Given this list of marker genes TRAPPC4, ADORA1, FZD3, PPFIA3, LPAR2, SYP, FLOT1, NAPA, RIMS1, CACNA2D1, RAB3A, SLC17A7, RIMS4, EGFLAM, ERC1, SYT1, STX19, GABRB1, PCLO, NUFIP1, SYT11, ITGA3, GRIA1, ADORA2A, PI4K2A, ERC2, APBA1, NTNG2, DAO, EHD1, CPLX3, CTNNB1, PPFIA4 (NCBI Gene Id 8497), PNISR, STX2, BRSK1, SV2A, RYK, NECTIN1, UNC13A, KCNJ8, GPM6A (glycoprotein M6A), P2RY1, CACNA2D3 (NCBI Gene Id 55799), GRM7, GPER1, CTNNA2, STX11, CTBP1, ARHGAP44, CACNA2D2, PPFIBP1, NTNG1 (netrin G1), PPFIA1, GRIN2D, STX1A, ADRA2A, BSN, RIMS2, ATP2B4, STX1B (syntaxin 1B), GUCY1B1, SYN1, UNC13B, TPRG1L, GAD1, STXBP1, P2RX1, UNC13C, SLC32A1, CDH10, PPFIBP2, LRFN3, KCTD8, HCN1, ADCY8, RIMS3, TRIO, PPFIA2, C1QBP, OSBPL2, here is a description of the gene set: studied in species Homo sapiens Human Gene Set: GOCC_PRESYNAPTIC_ACTIVE_ZONE A specialized region of the plasma membrane and cell cortex of a presynaptic neuron; encompasses a region of the plasma membrane where synaptic vesicles dock and fuse, and a specialized cortical cytoskeletal matrix.